Given this list of marker genes BAX, BAK1, CASP9, CYCS, CASP8, CASP3, BID, APAF1, here is a description of the gene set: Pathway Definition from KEGG: (Tat,Nef) -> CASP8 -> BID -> (BAX,BAK1) -> CYCS == APAF1 -> CASP9 -> CASP3 species: Homo sapiens HIV Tat/Nef to crosstalk between extrinsic and intrinsic apoptotic pathways. Pathway ID: N00449. Pathway type: Pathogen. Pathway class: nt06161 Human immunodeficiency virus 1 (HIV-1). Human Gene Set: KEGG_MEDICUS_PATHOGEN_HIV_TAT_NEF_TO_CROSSTALK_BETWEEN_EXTRINSIC_AND_INTRINSIC_APOPTOTIC_PATHWAYS